The following is a description of a gene set: Somatic mutations in nucleophosmin (NPM1) occur in approximately 35% of adult acute myeloid leukemia (AML). To assess the frequency of NPM1 mutations in pediatric AML, we sequenced NPM1 in the diagnostic blasts from 93 pediatric AML patients. Six cases harbored NPM1 mutations, with each case lacking common cytogenetic abnormalities. To explore the phenotype of the AMLs with NPM1 mutations, gene expression profiles were obtained using Affymetrix U133A microarrays. NPM1 mutations were associated with increased expression of multiple homeobox genes including HOXA9, A10, B2, B6 and MEIS1. As dysregulated homeobox gene expression is also a feature of MLL-rearranged leukemia, the gene expression signatures of NPM1-mutated and MLL-rearranged leukemias were compared. Significant differences were identified between these leukemia subtypes including the expression of different HOX genes, with NPM1-mutated AML showing higher levels of expression of HOXB2, B3, B6 and D4. These results confirm recent reports of perturbed HOX expression in NPM1-mutated adult AML, and provide the first evidence that the NPM1-mutated signature is distinct from MLL-rearranged AML. These findings suggest that mutated NPM1 leads to dysregulated HOX expression via a different mechanism than MLL rearrangement. Human Gene Set: MULLIGHAN_MLL_SIGNATURE_1_DN The 'MLL signature 1': genes down-regulated in pediatric AML (acute myeloid leukemia) with rearranged MLL compared to all AML cases with the intact gene. species: Homo sapiens from publication Mullighan CG, Kennedy A, Zhou X, Radtke I, Phillips LA, Shurtleff SA, Downing JR (PMID 17597811), and this is the list of marker genes: ADRM1, MAST4, BAALC (BAALC binder of MAP3K1 and KLF4), PGF, TIE1, MCF2L, KRT18, GTPBP3, BRD8, LAMB2, FUT2, STAP1, STAT5B, TBXA2R, STAT4, RIPOR1, FAH, CYTL1, FAAP20, HSPB2, SOX11, TGFBRAP1, RPL31, NBL1, ISYNA1, BTN3A3, PITPNB, RPS21, NIT2, PTGIR, LRP6, MAPRE2, TSHR, SERPINE2, LAMC3, CIR1, CD3D, BCKDHB, ADK, HSD17B12, ELMO1, KMT2A, SLC24A3, ISOC1, PPP1R16B, LUZP1, RPP40, HPGDS, EGFL7, SRSF5, APP, TRH, RPL13A, BIN1, SMARCA1 (NCBI Gene Id 6594), MCTP2, GSDMB, EDN2, NUDT11, CD99, SLC7A1, TPD52, ADNP2, ABCC4, POLE, FCER1A, TNPO2, MYH10, TNFRSF21, NPM1, CD200, DNAH2, PBX2, NPR3, HLF, MUC4, NET1, ITM2A, HNRNPA1P3, GTDC1, WASF1, SEPTIN11, MROH7, CD1E, PRF1 (NCBI Gene Id 5551), PYCR1, UBE2E1, YES1, ST18, ANP32CP, ATP2C1, SIDT1, AP1B1, CKB, CAV1, PTP4A3, SSX1, STAT5A, SIPA1L1, LAMA5, EFHC2, NUP50, CHD1L, TIMP3, GABRE, CEP170, FAM117A, DCUN1D4, MDK, CDH16, AGRN, STAM, MYRF, DNAJC12, HACD1, RXYLT1, CFAP410 (NCBI Gene Id 755), CCNG1, CLMN (calmin), C1orf174, BARX2, HSF4, CSAD, HGF, STXBP6, FAM171A1, BAIAP3, LOXL1, DPT, ATP2A3, OPN1SW, IFI44, DLC1, CYP2E1, RHOB, TREH, IL2RA, IFITM1, CXCL8, NAA16, CA4, AREG, STK32B, NOVA2, HOXB2, HS2ST1, TM4SF1, RUNX1T1, CXCL2, SLC13A3, KATNB1, ZMYND8, TTC3, MBIP, HPGD, PTPN14, TRIM24, TRIM16, P2RX3, ATP1B1, MANSC1, SMYD2, MYH11, CAVIN1, MACIR, CLIP3, RANBP2, JAK1 (NCBI Gene Id 3716), TSPAN7, MYO5C, AP5S1, NID2, RUNX1, EPS15, IGHV5-78, TPSAB1, SRP72, PPL, TRMT1, RPL36, TGFB1I1, CTDSPL, SYDE1, OLA1, POU4F1, TEAD4, DAPK1, DEPTOR, CHI3L1, MRC1, AQP4, HIP1R, PTH2R, JUND, TAL1, IFIT1, SPRY1, ZNF274, HYAL2, EFCAB6, ABHD10, MPL, FDFT1, USP34, PRKCQ, WDR59, ABCB1, BTG3, RBPMS, RASL10A, PMAIP1, PTPRCAP, EGR3, KIR3DL2, DLEU1, KRTAP5-8, ZSWIM8, ASAP3, LHFPL2, STOM, ITGAV (integrin subunit alpha V), NHERF2, NR2F2, METAP1, SLC12A4, EEF1D, GGT5, SLC18A2, FSCN1, BCAT1, PPT2, TFPI, MAF, MRPS2, CETP, MRPS22, MMP2